The following is a description of a gene set: studied in species Mus musculus Mouse Gene Set: GOBP_CELLULAR_RESPONSE_TO_OXYGEN_LEVELS Any process that results in a change in state or activity of a cell (in terms of movement, secretion, enzyme production, gene expression, etc.) as a result of a stimulus reflecting the presence, absence, or concentration of oxygen., and this is the list of marker genes: Dnmt3a, Gnb1, Pdcd10, Ndp, Commd1, Pten, Scn2a, Ado, Nop53, Mir491, Npepps, Dnm1l, Acvr2a, Foxo1, Tgfb1, Vegfa, Myc, Cbl, Atp6ap1, Cdkn1b, Bnip3l, Stc2, Nol3, Kdm6a, Suv39h2, Gata6, Hp1bp3, Slc29a1, Clca1 (chloride channel accessory 1), Rgcc, Adam8, Mir17, Trem2, Tmem199, Mstn, Ucn3, Usp19, Nkx3-1, Notch1, Oprd1, Mir207, Aifm1, Endog, Zfas1, Rock2, Epha4, Tigar, Bcl2, Atf4 (activating transcription factor 4), Egln1, Casr, Mir214, Cysltr1, Mir106a, Nox1, Pou4f2, Eef2k, Epas1, Mir199a-1, Chchd2-ps, Lmna, Vldlr (very low density lipoprotein receptor), Mtor, Stat3, Mir222, Src, Ddah1, Chchd2 (NCBI Gene Id 14004), Vasn, Mdm2, Tert, Nono, Higd1a, Cysltr2, Fndc1, Bbc3, Fam162a, Inhba, Becn1, Cbs, Pck1, Cav1, Kcnk2, Gngt1, Mir327, Mir379, Daxx, Mir668, Fabp1, Cybb, Phb2, Ngb, Zfp36l1, Aqp3, Rora, Mir199b, Dram1, Kcnk3, Vhl, Ajuba, Mst1, Mir150, Atp6v0d1, Ccna2, Adrb2, Eno1, Ak4, Mir199a-2, Mir204, Slc2a4, Ptprd, Ero1a, Trp53, Nfe2l2, Edn1, Ep300, Rtn4, Cr1l, Mir221, Mief1, Twist1, Egr1, Gad2, Ndrg1, Mir499, Drd1, Fmn2, Map1lc3a, P4hb, Ddr2 (discoidin domain receptor family, member 2), Fos, Mir21a, Bmyc, Angpt4, Mapk8 (mitogen-activated protein kinase 8), Sdhd, Mir874, Foxo3, Mgarp, Mlst8, Suv39h1, Mir146, Brip1, Atp6v1g1, Lpar1 (NCBI Gene Id 269543), Pdk3, Ndufs2, Kcnd2, Hif3a, Slc9a1, Eno1b, Pparg, Sfrp1, Fas, Drd2, Atp6v1a, Sirt4, Rwdd3, Hyou1, Myod1, B3gat1, Mir15b, Bad, Egln3, Pik3cb (NCBI Gene Id 74769), Slc8a3, Prkaa1, Atp6v0a2, Eif4ebp1, Atf2 (activating transcription factor 2), Pick1, Cited2, Cpeb1, Prkce, Pdk1, Acaa2, Mir223, Ppard, Hif1a, Ireb2, Ccdc115, Stc1, Ndnf, Mir20b, Pink1, Bnip3, Tmbim6, Mir31, Tsc1, Ptgis, Ndufs4, Sirt1, Ptgs2, Mir142, Aqp1, Egln2, Sirt2, Ubqln1, Rptor, Cpeb2, Tbl2, Carlr, Ptpn1, Hilpda, Cpeb4, Polr2a (NCBI Gene Id 20020), Akt1, Map2k1, Ogt, Atg7, Pgk1